The following is a description of a gene set: Human Gene Set: GOMF_C_X3_C_CHEMOKINE_BINDING Binding to a C-X3-C chemokine; C-X3-C chemokines have three amino acids between the first two cysteines of the characteristic four-cysteine motif. studied in species Homo sapiens, and this is the list of marker genes: ITGB3, CX3CR1, ITGAV, ITGB1, ITGA4